The following is a description of a gene set: Mouse Gene Set: GOBP_REELIN_MEDIATED_SIGNALING_PATHWAY studied in species Mus musculus The series of molecular signals initiated by the binding of reelin (a secreted glycoprotein) to a receptor on the surface of a target cell, and ending with the regulation of a downstream cellular process, e.g. transcription., and this is the list of marker genes: Pafah1b1, Crkl, Crk, Dab1, Stat5a, Lrp8, Fyn, Cul5, Vldlr, Reln, Rnf7, Fkrp